The following is a description of a gene set: Neighborhood of IL6ST Human Gene Set: GCM_IL6ST species: Homo sapiens Neighborhood of IL6ST interleukin 6 signal transducer (gp130, oncostatin M receptor) in the GCM expression compendium, and this is the list of marker genes: CRKL, SELENOI, RDX, GORASP1, ATMIN, PACS2 (phosphofurin acidic cluster sorting protein 2), ATP2B2, FAM219A, PREX1, PHAX, RAB22A, SH2B1, MYO9A, C1orf198, RTN4, ERBIN, MTMR4, KIF3B, CCDC25, SPRED2, MYO10, TNS2, NAPG, TBC1D10B (NCBI Gene Id 26000), IPO5, ACAD11, EFCAB14, GLT8D1 (glycosyltransferase 8 domain containing 1), CLDND1, XPOT, ANKFY1, GOLM2, MAP4K4, FBXW11, AIDA, PJA2, KCNJ10, WSB1, TMED5, ARL8B, CHST10, GFM2, MTCH2, SIRT2, GLTP, TSNAX, TMEM30A, TACC1, GOLGA7, IL6ST, DYNC1LI2 (dynein cytoplasmic 1 light intermediate chain 2), LANCL1, DLG1, DDHD2, TEX261